The following is a description of a gene set: Mouse Gene Set: GOBP_TYPE_I_HYPERSENSITIVITY species: Mus musculus An inflammatory response driven by antigen recognition by antibodies bound to Fc receptors on mast cells or basophils, occurring within minutes after exposure of a sensitized individual to the antigen, and leading to the release of a variety of inflammatory mediators such as histamines., and this is the list of marker genes: Ighg2b, Fcer1a, Fcgr3, Fcgr2b, Btk, Ighe, Ighg1, Fcer1g